Given this list of marker genes TRMT61A, TRMT11, TRMT61B, WDR4, TRMT112, TRMT6, HSD17B10, THUMPD2, THUMPD3, TRMT10C, METTL1, here is a description of the gene set: studied in species Homo sapiens A multimeric protein complex involved in the methylation of specific nucleotides in tRNA. Human Gene Set: GOCC_TRNA_METHYLTRANSFERASE_COMPLEX